The following is a description of a gene set: studied in species Homo sapiens from publication Buxadé M, Lunazzi G, Minguillón J, Iborra S, Berga-Bolaños R, Del Val M, Aramburu J, López-Rodríguez C (PMID 22312110) Human Gene Set: GSE26343_UNSTIM_VS_LPS_STIM_MACROPHAGE_UP Gene expression from WT and NFAT5 KO primary macrophage cultures. Genes up-regulated in bone marrow-derived macrophages: control versus stimulated with LPS., and this is the list of marker genes: CMTM6, MED13L (NCBI Gene Id 23389), UTP4, CCDC38, C19orf12, RRS1, SLC30A4 (NCBI Gene Id 7782), ZFP36, NMD3, CD40, CACNB2, SLC1A5, STAP1, MAP3K8, HIVEP3, MCF2L, DLGAP1, NFIL3, PSMB7, TLCD3A, DIAPH1 (NCBI Gene Id 1729, diaphanous related formin 1), CD300LF, EML4, FBLN2, PUS7, MOB3A, STK40, HRAS, HLA-DMA, TOR1AIP2, RRP15 (NCBI Gene Id 57241), CSF2, SEMA7A, GPATCH4, RNF24, TGFB1, ELOVL7 (ELOVL fatty acid elongase 7), LASP1, ST6GALNAC4, EMG1, SIAH2, VCAN, ISY1, PUS1, PROCR, B3GNT7, SET, NOL12, AHR, MRI1, COX17, IFI35, ATP5MG, ST7 (suppression of tumorigenicity 7), SOCS1, NFKBIB, MLLT6, BATF2, ARID5A, ABTB2, PWP2, UBTD2, FBL, RSL1D1, C1orf131, RALGDS, LTF, SFRP4, GAR1, REXO2, BTF3, NOC2L, RWDD1, OPN3, RASGEF1B, RAI14, PLA1A, NOL6, CXCL2 (C-X-C motif chemokine ligand 2), PXDC1, SUB1, UPK1B, MAT2A, CD83, CDC42EP2, CSF2RB, ECE1, HILPDA, SNRPA, CEMIP2, GNL3, PFKP, MMP13 (NCBI Gene Id 4322), RASA2, TXNRD1, RASA1, TIAM1, NSUN2, NXN, ZBP1, CHD7, ACTN1, FNDC3A, KDR, HSPA8, AHCY, ZNF507, EIF6 (NCBI Gene Id 3692), RGS1, KAZN (NCBI Gene Id 780789), DOK2, NIFK, ASAP1, QPCT, UBE2M, F10, BCAR3, HNRNPA3, SLCO3A1 (NCBI Gene Id 28232), DAXX, BASP1, OSTC, ELMO3, ALDH1B1, SNHG17, VCAM1, IFRD2, SERTAD2, FMNL2 (formin like 2), PRDX6, OCSTAMP, DDX39A, TIMM8A, FCGR2A, LYRM1, AARD, TRAF5, APEX1, UCK2, ERH, ATP6V0A1, SRGN, NAAA, RCL1, NSMF, FLRT2, SLC7A11, SNRPD3, PPP1R14B, CD209, RIPK2, DUSP6, DCUN1D3, S100A6, KLHDC4, PTGS2, RBPJ, GLIPR2, C11orf24, FAM217B, PNO1, NME1, PLAU, FCF1, NFKBIZ, PLXDC2, CASP7, INHBA, RBMXL1, PLA2G15, CMKLR1, EMP1, CCDC86 (NCBI Gene Id 79080), BATF, HLA-DMB, PIK3CG, CDH1, B3GNT2, IL1RN, DKC1, MREG, TMEM154, AEN, GART, SLC35B3, RPP40, SND1, CHST6, PRMT1, DDX1, TMA16, NPM1, IRF4, LRP8, FUBP1, CTDNEP1, DENR, TFEC, CLDN3, EEF1G